Given this list of marker genes RECQL5, FAN1, SMC6, RPA2, MUS81, XRCC1, MLH1, RAD51D, SPO11, DDX1, POLA1, ATP23, IFFO1, XRCC4, KDM2A, EPC2, HELQ, CDC7, MRE11, FMN2, SFPQ, KMT5B, PPP4C (NCBI Gene Id 5531), RAD54L, NSD2, TERB2, AP5Z1, INO80, USP51, BCL7B, RPA1, RADX, POT1, POLM, CDCA5, FBH1, PRMT1, ANKLE1, PARP9, PRDM9, GEN1, LIG4, CDC45, NSMCE1, ARID2, SMARCAD1, TIMELESS, TRRAP, NBN, RECQL4, ASTE1, PPP4R3C, KDM4D, AP5S1, NABP2, UBQLN4, RHNO1, SPIDR, ACTR2, SETD2, DPF3, HSF1, SAMHD1, RIF1, WRN, EYA3, DDX11 (NCBI Gene Id 93260), PRPF19, DMC1, SLX4, EPC1, FIGNL1, SLF2, RPA4, MCM8 (minichromosome maintenance 8 homologous recombination repair factor), SETX, UBE2V2, PNKP, DNA2 (NCBI Gene Id 1763), CHEK2 (checkpoint kinase 2), BRCA1, MPND, MCM7, HMCES, KASH5, ATM, SIRT6, PAXX, MSH2, HELB, MCM4, PELI1, BRIP1, ERCC6L2, H2AX, POLQ, TERF2IP, SPIRE1, NHEJ1, RECQL, OTUB1, C1QBP, FOXM1, MCM2, FH, PPP5C, WAS, UVRAG, REC8, SMARCA2, ZCWPW1, SWI5, RNF169, XRCC3, ATRIP, HUS1, SMARCA4, DCLRE1B, MAGEF1, DTX3L, NSMCE4A, MRGBP, ZNF365, PLK1, MORF4L1, SFR1, RFWD3, SMARCD2, MMS22L, HMGB2, CSNK2A2, ABRAXAS1, HMGA2, KAT5, BCL7A, RNF168, CHEK1, SMARCC1, MAJIN, YY1, GINS4, RAD50, RAD51C, EID3, ERCC1, CSNK2A1, TENT4A, RAD51AP1, MARF1, MGMT, PPP4R3B, WRAP53 (WD repeat containing antisense to TP53), OGG1, ZGRF1, FUS, REV3L, SLX1B (SLX1 homolog B, structure-specific endonuclease subunit), SHLD3, EYA1, TOPBP1, BLM, SMARCE1, ZMYND8, ACTL6A, TDP2, PML, APLF (NCBI Gene Id 200558), CREBBP, MCM5, TDP1, BRD8, FANCM, SIRT1, DCLRE1A, KHDC3L, HMGB1, KMT5C, ACTR8, HPF1, NUCKS1, PPP4R2, HSF2BP, CGAS, ZFYVE26, ERCC6, DPF2, NSMCE2, BCL7C, SHLD1, MBTD1, SMARCAL1, VCP, PIAS4, FANCD2, HDGFL2, OOEP, NUDT16L1, SMARCB1, CYREN, KLHL15, MAD2L2, PRKDC, FANCB, XRCC2, NIPBL, MEIOC, CSNK2A3, EME2, ACTR5, TWIST1, RAD54B, UHRF1, UIMC1, TOP2B, MTA1, SMARCC2, PSMD14, AUNIP, SETMAR, POLB (NCBI Gene Id 5423), UBE2N, RMI2, MCM3, RNF138, PARP2, TEX15, BABAM1, MRNIP, PARPBP, TP53BP1, KMT5A, ACTB, VPS72, RBBP8, SENP3, TONSL, TOP3A (DNA topoisomerase III alpha), SLF1, RAD21, SMC5, MORF4L2, ZBTB7A (NCBI Gene Id 56976), EP400, MIR221, MEIOB, INTS3, RMI1, BRCA2, ESCO2, FEN1, PHF10, ACTL6B, RAD51, RTEL1, SMARCD1, SMCHD1, BRD7, TRIP13, RUVBL2, TNKS1BP1, ARID1B (AT-rich interaction domain 1B), RNF126, CIB1, RAD21L1, MEAF6, SHLD2, RNF8, PALB2, NABP1, PARP3, BABAM2, SMARCD3, C14orf39, GINS2 (GINS complex subunit 2), MCMDC2, EME1, SPIRE2, RAD52, PBRM1, POLN, DPF1, BRCC3, RUVBL1, ERCC8, LIG3, CHD4, INIP, POLL, SLX1A (SLX1 homolog A, structure-specific endonuclease subunit), ZSWIM7, NSMCE3, MCM6, GGN, BRME1, XRCC6, DNTT, SEM1, AGER, TP53, SWSAP1, DCLRE1C, TFIP11, SKP2, WDR48, DEK, DMAP1, MCM9 (NCBI Gene Id 54844), PPP4R3A (NCBI Gene Id 84644), ING3, EXD2, TERB1, PARP1, KDM1A, YEATS4, POGZ, HUS1B, ATR, XRCC5, RPA3, HTATSF1, ARID1A, ERCC4, ABL1, RAD51B, ERCC5, here is a description of the gene set: studied in species Homo sapiens The repair of double-strand breaks in DNA via homologous and nonhomologous mechanisms to reform a continuous DNA helix. Human Gene Set: GOBP_DOUBLE_STRAND_BREAK_REPAIR